Given this list of marker genes Npr2, Ppp2r1a, Ythdf2, Lsm14b, Grb14, Ednra, Nppc, Edn1, here is a description of the gene set: Mouse Gene Set: GOBP_MEIOTIC_CELL_CYCLE_PROCESS_INVOLVED_IN_OOCYTE_MATURATION Any meiotic cell cycle process that is involved in oocyte maturation. species: Mus musculus